The following is a description of a gene set: Any process that results in a change in state or activity of a cell or an organism (in terms of movement, secretion, enzyme production, gene expression, etc.) as a result of an iron(II) ion stimulus. species: Mus musculus Mouse Gene Set: GOBP_RESPONSE_TO_IRON_II_ION, and this is the list of marker genes: Map1lc3a, Lct, Snca, Becn1, Aco1, Atg5, Gpld1, Pdx1